Given this list of marker genes BUB1B, AURKB, KIF2C, KIF20A (NCBI Gene Id 94421), MCM4, CDC20, RANBP1, CHAF1B, BUB1, RRM2, CENPE (NCBI Gene Id 1062), FOXM1, PLK1, MELK, SMC2, ASPM, ESPL1, CDCA8, HMMR, SPAG5, CKS1B, CDT1, ASF1B, GMNN, CCNB2, NDC80, here is a description of the gene set: Neighborhood of BUB1 BUB1 budding uninhibited by benzimidazoles 1 homolog (yeast) in the GNF2 expression compendium species: Homo sapiens Neighborhood of BUB1 Human Gene Set: GNF2_BUB1